Given this list of marker genes VKORC1L1, RRM2B, RRM2, VKORC1, RRM1, here is a description of the gene set: studied in species Homo sapiens Human Gene Set: GOMF_OXIDOREDUCTASE_ACTIVITY_ACTING_ON_CH_OR_CH2_GROUPS_DISULFIDE_AS_ACCEPTOR Catalysis of an oxidation-reduction (redox) reaction in which a CH2 group acts as a hydrogen or electron donor and reduces a disulfide group.